The following is a description of a gene set: A broad range of compulsive behaviors are repeated, including simple motor stereotypies and tics, as well as more complex repetitive movements or compulsions. Human Gene Set: HP_RESTRICTED_OR_REPETITIVE_BEHAVIORS_OR_INTERESTS species: Homo sapiens Restricted or repetitive behaviors or interests, and this is the list of marker genes: NPC2, VCP, CACNA2D1, TCF4, WDR4, DHPS, KAT5, CDKL5, VPS13A (NCBI Gene Id 23230), HNRNPH2, ATRX, ARID2, ZFX, ITPR1, TRIM8, KMT5B, TPR, BICRA, LRAT, TUBB3, UBE3A, SPEN, KMT2A, NAA60, OPHN1, DLL1, CCNK (NCBI Gene Id 8812), KCNN2, AP1S2, NAA20, CHD8, ELP2, PDPN, VAMP2, GNB2, TAOK1, MACF1, DYRK1A, TBX1, CTBP1, ZEB2, ZBTB18, KYNU, FOXP1 (NCBI Gene Id 87246), ZSWIM6, NIPBL, TRANK1, NEXMIF, VARS1, PSEN1, DHX30, FBXO28, GABBR2, ANK3, GABBR1, GDF6 (growth differentiation factor 6), CAMK2B, CASK, NAT8L, MECP2, SNRPN, ATG7, HUWE1, BCL11A (BCL11 transcription factor A), PRDM16, CHAMP1, GRN, SLC1A4, POGZ, CERT1 (NCBI Gene Id 10087), CHD3, ZNF526, DPF2, GABRG2, NMNAT1, YME1L1, DPAGT1, EEF1A2, LCA5, GRIN2A, GJA8, TRIO, DNAJC19, DDX6, SPATA7, PGAP3, NAA15, CRB1, CHRNA2 (NCBI Gene Id 1135), ATP9A, RAC1, FBXW11, ASXL3, SMARCA2, TTI2, PUS7, CRELD1, UBE4B, CRH, PCYT1A, GJA5, SATB1, TMEM222, EP300, EHMT1, SPTBN1, PGAP1, NLGN4X, ZMYM2, AP4B1, FGFRL1, CIC, LETM1, DOCK7, BRAF, DDC, THOC2, MAPT, SMC1A, HNRNPK, IQCB1, NARS1, NTNG1, PPP2CA, PTRHD1, GNAI1, TCF20, CHMP2B, TBCD, GRIN1, PPP2R5D (protein phosphatase 2 regulatory subunit B'delta), TRAPPC6B, CHRNA4, OCRL, GABRB3, TBC1D23, UBAP2L, DEPDC5 (NCBI Gene Id 9681), CRX, RPE65, SLC4A10, NTNG2, ADNP, TAF4, CAMTA1, RFX7, TMEM67, ALKBH8, NSD2, AFG2A, FLII, CHRNB2, PUF60, CSNK2A1 (casein kinase 2 alpha 1), NTRK2, GABRD, CELF2 (CUGBP Elav-like family member 2), TARDBP, CEP85L, RAB11B, RPGRIP1, MYT1L, DPYSL5, NACC1, SIK1, RAB39B, IQSEC2, MEF2C, HSPG2, LARP7, GRIK2, RTTN, TUBB4B, ARPC4, RAI1, AP4E1, AP4M1, SLC6A8, TREM2, EIF4A2, FOXG1, SYT1, AGO1, RERE, NAA10, NDP, ZBTB20, JRK, PDZD8, CABP4, NR2F1, GABRA1, SYNGAP1, SHMT2 (NCBI Gene Id 6472), MAPK1, EXT2, TULP1, CPLX1, RD3, PUM1, AIPL1, TFE3, EXTL3, RHOBTB2, POLA1, HNRNPR, PRODH, BCORL1, RDH12, EBF3, CDK19, SLC9A6, CLCN3, DEAF1, FLCN, KCNJ13, MMP23B, AUTS2, PRKAR1B, KIF5C, HERC2, SVBP, GUCY2D, CNTNAP2, SLC2A1, IFNG, IMPDH1, TSC1, SCN1A, TSC2 (NCBI Gene Id 7249), CACNA1H, KCNT1, NLGN3, ASH1L, WDR26, WBP4, CTCF, ADGRL1, CHD1, HDAC4, LMNB1, NAGS, HTT, GRIA2, KIF15, FMR1, SKI, H4C5, SQSTM1, IFT140, USP45, HECW2, CREBBP, OCA2, TANC2, AHDC1, PACS2, PDE2A, SOX5, RBL2, CACNA1B, KCNAB2, NOVA2, SHANK3, NAPB, KAT6A, TBR1, TRAPPC9, TCEAL1, CASZ1, TKT, MGAT2, KPTN, MBD5, AFF3, CEP290, MADD, KCNB1 (NCBI Gene Id 3745), PIGF, SH2B1, CUX2, TMEM106B, LUZP1, AP4S1, PRKCZ, RNU4-2, AFF2, GLYCTK